Given this list of marker genes B4galt7, B4galt1, B4galt3, B4galt2, Wdfy3, here is a description of the gene set: studied in species Mus musculus Mouse Gene Set: GOMF_BETA_N_ACETYLGLUCOSAMINYLGLYCOPEPTIDE_BETA_1_4_GALACTOSYLTRANSFERASE_ACTIVITY Catalysis of the reaction: UDP-galactose + N-acetyl-beta-D-glucosaminylglycopeptide = UDP + beta-D-galactosyl-(1->4)-N-acetyl-beta-D-glucosaminylglycopeptide.